Given this list of marker genes SYTL2, CLN3, DUSP5, TKTL1, MKI67, METRNL, EML3, CRIP1, SAMHD1, ENTPD1, SOCS2 (suppressor of cytokine signaling 2), NOD1, SERPINB1, ATP8A2, BST2, ITGB7, IER3, RACGAP1, TXNDC5, SLC66A3, CTSC, S100A6, ITGAX, EFHD2, IGFBP6, HRH4, PRRG4, RUNX3, INPP5D, F2RL2, NAALAD2, PIK3AP1, APOBR, VIM, HID1, CXCR6, PYGL, HSD11B1, YES1, PRDM1, DNAJC15, IKZF3, GGT1, DENND5A, ADGRG3, PAK6, LGALS3, KCNJ8, EPSTI1, C15orf48, DTX1, SEPTIN8, YBX3, SGK1, GZMA, ITGB3, RASL11A, DEPDC1B, CCR2, IFITM2, PLEKHM3 (pleckstrin homology domain containing M3), RCBTB2, TAFA3, RARA, IL2RA, SELPLG, USP48, PADI2, SLAMF7, MVB12A, IL2RB, FES, LPIN1, KIF11, EIF4E3 (NCBI Gene Id 317649), SLC9A8 (NCBI Gene Id 23315), MYADM, VARS1, NIBAN2, FBXO30, NHSL2, N4BP3, IFITM3, CCRL2, COBLL1, ATP8B4, HAAO, MYL4, FASLG, SWAP70, STMN1, CCR5, B4GALT1, GPC1, IQGAP2 (IQ motif containing GTPase activating protein 2), PLP2, CYP3A7, EHBP1L1 (NCBI Gene Id 254102), GOLGA3, P2RY14, CCL5, F2R, LAIR1, NRARP, CSF2, PLAC8, KLRK1, IL12RB2, AHNAK, SLC41A2, MYO1F, ADAM8, CLDND2, ADAM19, BHLHE40, IL10RA, RMDN2, TPST2, RPA2, NEDD4, CERCAM, PAQR8, CRYBG2, ZYX, ITGA1, KCNK5, CTSW, S1PR5, PILRB, CHSY1, TMEM37, GALNT3, GABARAPL2, SEPTIN10, GLUD1 (glutamate dehydrogenase 1), LGALS1, GATA3, PRUNE1, MPND, MYO1G (myosin IG), AQP9, FCGR2B (NCBI Gene Id 2213), HM13, SMPDL3B, MX2, GAS7, IL18R1, NLRC3, FHL2, NCAPG, CCND3, GZMM, SLBP, RAP1GAP2, GRAMD2B, NUDT4, PLEK, GNA11, OSTF1, BCL2, KLRC1, CDH1, CD7, CD47, GMNN, EDARADD, RCN1, ACTN2, LDAF1, SLC2A3, ITSN1, SLCO3A1, KATNB1, NKG7, GAB3, RRAS, ROM1, RBCK1, ZEB2, ARHGAP18, GZMB, ABTB3, ANXA1, CA5B, NBEAL2, PTPN2, ARL4D, FAM111A, CXADR, GALNT10, DOCK5, KLRG1, FRY, CHAF1B, DKKL1, SLC30A7, KLRD1, PAICS, CKS2, PRKAB2, here is a description of the gene set: from publication Castro I, Dee MJ, Malek TR (PMID 23018461) Much is known concerning the cellular and molecular basis for CD8+ T memory immune responses. Nevertheless, conditions that selectively support memory generation have remained elusive. Here we show that an immunization regimen that delivers TCR signals through a defined antigenic peptide, inflammatory signals through LPS, and growth and differentiation signals through the IL-2R initially favors antigen-specific CD8+ T cells to rapidly and substantially develop into tissue-residing T effector-memory cells by TCR transgenic OVA-specific OT-I CD8+ T cells. Amplified CD8+ T memory development depends upon a critical frequency of antigen-specific T cells and direct responsiveness to IL-2. A homologous prime-boost immunization protocol with transiently enhanced IL-2R signaling in normal mice led to persistent polyclonal antigen-specific CD8+ T cells that supported protective immunity to Listeria monocytogenes. These results identify a general approach for amplified T memory development that may be useful to optimize vaccines aimed at generating robust cell-mediated immunity. Gene expression analysis was performed for OT-I T cells on day 3 and day 5 after activation with ovalbumin and LPS in vivo with and without treatment with IL-2 using an agonists IL-2/anti-IL-2 complexes (IL2/Jes-6.1) Human Gene Set: GSE39110_UNTREATED_VS_IL2_TREATED_CD8_TCELL_DAY6_POST_IMMUNIZATION_UP species: Homo sapiens Genes up-regulated in CD8 T cells 6 days after immunization: control versus IL2 treatment.